The following is a description of a gene set: Mouse Gene Set: ZFP708_TARGET_GENES species: Mus musculus from publication Yevshin I, Sharipov R, Kolmykov S, Kondrakhin Y, Kolpakov F (PMID 30445619), and this is the list of marker genes: Malat1, Aloxe3, Kcnh6, 6820431F20Rik, Adipor1, Spata31e2, Tnrc18, Ifrd1, Bcan, Lhx3, Syt14, Ssbp3, 4930554H23Rik, Cntnap5a, Ipmk, Pabpc1, Lin28a, Vip, Rab3c, Dlg4, Zfp579, Inpp5f, Cacng3, Mtag2, Thpo, mt-Tq, Hhatl, Mid1, Dnajc9, Katnb1, Nefm, Zfp661, Kcns2, Calb1 (NCBI Gene Id 12307), Gm13163, Fzd1, Htr5a, Zfp641, Sptbn4, Aire, Cnga3, Lrp3, Plcd4, Tbp, Tmem198, Gfm1, Tsen54, Sfi1, Paf1, Pvr, Gm7153, Gsx1, Cpne9, Fzd2, Drd2, Polr2b, Sh2d3c, Ptk2b, Vgf, Grid2ip, Ramp2, Tbkbp1 (TBK1 binding protein 1), Mblac2, Tti2, Bsx, Kctd10, Cntnap2, Mir1932, Gm11100, Rragb, Lbx1, Chrnb2, Stxbp5l, Gm26504, Kcnj2, Lexis1, Bdnf, Polr3g (NCBI Gene Id 67486), Nacad, Snord13, Ctdsp2, Ube3b, Scg5, Celf3, Ythdf3, Gls, Tph2, Gm15787, Marchf4, Aebp1, mt-Tw, Gm3242, Scg2, Unc80, Kcnt1, Lamc3, Hmg20b, Ap2b1, Pclo, Glra1, mt-Nd1, Gria2, Mir9-2hg, Rasa4, Kcnk3, 4933415A04Rik, St8sia3, Zfp36, Srrm3, Mir9-3hg, Pgbd5, mt-Tl1, Tppp, Lrp11, Lrrc24, Hmgn2, Mir6236, Cyp51, Amer3, mt-Nd5, Rph3a, Gbx2, Cplx3, Gm2427, Hpca, Syndig1l, Noa1, Glra2, Neurod4, Akap13, AA467197, Tmem191, Slc8a2, Krt86, Yif1a, Chpf, Tex14, Mnat1, Ckmt1, Cyb5rl, Celf6, Ccdc92b, Sez6, mt-Nd2, Gps2, Actn2, Acsl6, Mbd1, Fstl5, Bicdl1, Synj1, Pcsk2os1, Kcnb1, Cpne4, Tmc4, Olfm3, Tsr3, Mapk11, Ttc9b, AU040320, 2900052L18Rik (NCBI Gene Id 76835), Gm8357, Psmd1, Pax5, Nptxr, Gm17916, Usp13, Gm13421, Lbh, Rnu11, Ankhd1, Alyref2, Pex5l, Cul5, Mir9-2, Kcnc1, Ccdc184, Sez6l2, Fam135a, Caskin2, Adgrb3, Ncdn, Rundc3a, Six6, Cacng2, Scg3, Mir7b, Barhl1, Cntnap5c, Rpl23a, 2610005L07Rik, Gm25628 (predicted gene, 25628), Gm9918, Npas1, Sco2, Vwc2l, Actl6b, Vps54, Gm37450, Gad2, Dlgap1, Aifm3, Mapk8ip1, Gm3084, Cntnap5b (contactin associated protein-like 5B), Duxf1, Gm15564, Acox3, Cimap2, Pnkd, Grm1, Snord42b, Pcsk1, Prune2, Htr1a, Snord118, Snrk, Scn2a, Dynll2, Kmt5b, Prmt5, Mir132, Ghsr (NCBI Gene Id 208188), Zcchc14, Golga3, mt-Th, Mfsd4b3-ps, Fads1, Nrxn2, Pik3r3, Pde4d, Eapp, Cnrip1, Svop, Hes2 (NCBI Gene Id 15206), Grin1 (NCBI Gene Id 14810), Nrxn1, Hnf1aos1, Meis3, Tmprss13, Smim5, Odad1, Scrt1, Slc17a6 (solute carrier family 17 (sodium-dependent inorganic phosphate cotransporter), member 6), Laptm5, mt-Tv, Gprin1, Mir449c, Tbc1d14, Nucb1, Ucn, Hes1, Platr9, Nppb, Cartpt, Sntg1, Fkbp5, Slc16a3, Gm3453, Grm2, Cep250, Asphd1, Lrrc18 (NCBI Gene Id 67580), Mtrfr, Dner, Atp6v1b2 (ATPase, H+ transporting, lysosomal V1 subunit B2), Zfp90, Tspan1, H2-T23, Pdcl, Fcgrt, Asic3, Cyb5r4, Ctnnbl1, Lhfpl5, Ifnz, Mterf2, Adcyap1, Pnisr, Rell2, mt-Tl2, Ankrd24, Kcnk18, Slc26a5, Sppl3 (signal peptide peptidase 3), Scamp5, Disp2, Cdk5r1, Pip5k1c, Gpr158 (NCBI Gene Id 241265), Celsr3, mt-Ts2, Slc39a3 (NCBI Gene Id 208667), Guf1, Gm15912, Dnajc11, Akain1, Gcnt2, Unc13a, 1110018N20Rik, Rab39, Gm35025, Dnajc6, Prlhr, Ctbp1, Mir761 (NCBI Gene Id 791075), A630050E04Rik, Scn3b, Fbll1, Scap, 3110031N09Rik, Gm25541, Ptprn2, Cpxm2, Veph1, Oprm1 (opioid receptor, mu 1), Slc5a11 (NCBI Gene Id 72066), Adam19, Gm16099, 5330439K02Rik, Gpr19, Gm15247, G530011O06Rikx, Nxph1, Npdc1, Gm10222, Hrh3, Rab1a, Grin2a, Syp, Snord3a, Apela, Shank1, Fkbp7, Car3, Gm11399, Pias3, Katna1, Mir212, Omg, Nell2, Ogdhl, Lima1, Fam163b, 1700101I19Rik, Apcdd1, Osbp2, mt-Rnr2, Nme4, Selenoi, Mapk8ip2, Car10 (carbonic anhydrase 10), Psd, Kcnk12, Cadps, Chka, Ctxn2, Myo18a, Gm6089, Gm15320, Trpc7, Gtf3c6, Gm31693, A930029G22Rik, Elovl2, Hs3st2, Fis1, H6pd (hexose-6-phosphate dehydrogenase (glucose 1-dehydrogenase)), Zfp672, Med29, Unc79, Tmem179